The following is a description of a gene set: Human Gene Set: HP_ABNORMAL_ESOPHAGUS_PHYSIOLOGY Any physiological abnormality of the esophagus. species: Homo sapiens Abnormal esophagus physiology, and this is the list of marker genes: VPS37D, AGO1, RET, CACNA1A, AMER1, CHRND, GCLC, TERT, ARHGEF38, GTF2IRD1, EEF1A2, TMTC3, NDUFAF2, VAPB, COL2A1, TBC1D23, SYT2, LRRK2, WAC, CDON, MT-ND1 (NCBI Gene Id 4535), MEN1, ADAMTS2, NEPRO, MGME1, SLC25A1, MT-ND3, LYRM4, WARS2, CACNA1I, STX1A, LUZP1, ERCC6, CNKSR2, GNB5, UNC13A, SLC25A22, CDKN1B, FKBP6, UNC45B, PDPN, SYNJ1, MT-ND5 (NCBI Gene Id 4540), SLC1A3, ASCC3, NEXMIF, ATXN2, SON (NCBI Gene Id 84155), SPG21, FZD2, PRUNE1, HNRNPK, AOPEP, SPTAN1, GPHN, TUBB6, PACS2, ATG7, SEC63, RIC1, SDHB (NCBI Gene Id 96200), KAT6A, ACTB, CDC6, PRDM16, TBC1D24, PGM3, KLHL7, CRYAB, FARS2, ZSWIM6, AAAS, OPA1 (NCBI Gene Id 4976), RETREG1, PIGN, CLCN1, ATP7A, TTC19, FAM13A, TFAP2A, SCUBE3, MYMK, CACNA1C, DAB1, NDUFA13, ARHGAP29, AFG3L2, FARSB, NOP56, SMC5, CACNA1B, POLR3B, TFG, SLC25A24 (NCBI Gene Id 92093), ATXN7, SACS, ARSL, TYMP, TECPR2, TAMM41, YARS2, CASK, SMG9, ITPR1, GABRG2, SPART, YY1, CCDC22, KAT6B, BRAF, GUCY1A1, ATP6V0A1, CPLX1, PUS3 (pseudouridine synthase 3), MAP3K20, LAMA2, ARCN1, NEFL, PRPH, ALG2, NDUFA9, GLI2, ALMS1, MB, NSD2, TRAPPC11, ARF1, PARN, POLR3A, MECP2, DHX9, NDUFA6, EXOSC5, EDEM3, CRLF1, FOXH1, SPG11, CNTNAP1, MT-ATP8, LMNB1, DNAJC30, CSPP1, SPEN, PIK3R5, ADGRG1, GAS1, DNM1, PABPN1, CLIP2, MEGF10, MTHFS, ZIC2, BMP4, GRB10, SETX, SLC46A1, BICRA, PPM1D, SIN3A, COQ4, SLC5A7, TANGO2, MED17, NOS1, TPM3, ARNT2, NTRK2, DISP1, CYP27A1, NKX2-5, COL4A6, BAP1, SLC1A4, ACTA1, GTF2IRD2, CLCA4, PTCH1, SUCLG1, KLHL41, NSUN2, TMEM94, TPM2, TBX4, PTRHD1 (NCBI Gene Id 391356), PRKCSH, ACTL6B, ABCD1, ATP2B3, VPS13A, RAD21, SEC24C, GABRB2, SLC25A4, FBXO7, CTBP1, LRPPRC, HECTD4, ATP7B, SLC6A5, AGR2, SPTLC2, TERC, PRDX3, CHRNE, SMARCA2, SPTBN4, DMXL2, TCEAL1 (NCBI Gene Id 96422), CACNA2D1, MAGEL2 (MAGE family member L2), FGF12, COL1A1, HNRNPH2, GFAP, APOE, MYPN, SRPX2, KY, AFG2A, RNU4-2, GRHL2, CDK13, SCN1B, DNAJB6, AHDC1, KCNA1, CCR6, FGF8, PIGP, ANKRD11, TGM6, SZT2, FMR1, PLA2G6, SLC13A5, ASXL3, CTNNB1, DST, COL13A1, FLCN, TMEM270, PDE8B, UCHL1, ZC4H2 (zinc finger C4H2-type containing), COX11, NPC1, MYO9A (myosin IXA), POR, QDPR, WDR26 (WD repeat domain 26), GCH1, GLYCTK, KIAA0586, HEXB, CDK19, ACADVL, ENSG00000288330, SLC1A2, NFIX, MMP23B, EP300, ALS2, GFPT1, PIEZO1, TAF6, PRPS1, ATXN3, RARS1, PYROXD1, FTL, CHCHD10, ARID2, KMT2B, HMBS, SDHD, UBA5, CAMK2B, EIF5A, SYT14, MT-TL1, LTBP4, HLA-B, CFAP410 (NCBI Gene Id 755), CSF1R, WWOX, CENPT, CASZ1, GBA1, VAC14, GLRA1, FLVCR1, SEC31A, MYOT, STAC3, LETM1, DLL1, MPZ, CAV1, NECAP1, ANXA11, APC2, MAP1B, DDOST, TGIF1, TSEN2, HLA-DQB1, FLII, SMC1A, KCNK9, RHBDF2, TNPO3, GRIN2D, BRD4 (bromodomain containing 4), KCNC2, HRAS, ATL3, NEU1, SCN8A, HGSNAT, CORO1A, CREBBP, DEAF1, VAMP1, DKK1 (NCBI Gene Id 22943), CHMP2B, GDAP2, AFF4, ATP1A3, UBE4B, ELP1, EPG5, STAG2, ABCA3, NEUROD2 (neuronal differentiation 2), PDHA1, PFN1, SHANK3, CHAMP1, DYSF, GABBR2, MAB21L1, TIMM8A, DPP9 (dipeptidyl peptidase 9), SCN9A, ITCH, SRD5A3, SERPING1 (serpin family G member 1), TPP1, SLC35A2, KCNQ2, HIRA (histone cell cycle regulator), SYT1, SNF8, MAPT, SLC26A9, AMPD2, ITGA7, STAG1, RNASEH1, NECTIN1, TP63, DDHD2, TBX1, MEIS2, PRKRA, KIF5A, HDAC8, PIGT, MFF, NSRP1, ARVCF, SCN4A, ATXN10, ZMYM2, MT-TT, FLNC, GNAQ, SCN1A, PSEN1, MAPK8IP3, AFF3, EXT2, AP3B2, ASPA (aspartoacylase), ATP6V1B2, IDH1, MBD5, ACTG2, COL5A2, SCARB2, PHEX, ERMARD, SCN3A, GRIA1, NF1, KNSTRN, RPL10, DPH5, ARX, SFTPA2, CELF2, CYFIP2, SI, SLC19A3, SQSTM1, TRPV6, KCND3, RRM2B, SLC52A2, ACOX1, NEDD4L, RRM1, SLC6A9, ADAT3, PORCN, POLG, ASNS, H3-3A, WFS1, UFC1, GMPPA, PNKP, TUBB4A, LMNA, PAX8, LMX1B, PEX1, TRIO, PANK2, MED12, COLQ, CDKL5, GABRA2, NEB, CTNS, DLG1, CAMTA1, MIF, GTF2I, LRP12, CHAT, NUP62, NGLY1, ALG12, BAZ1B, CLTC, USP7, H3-3B, IRF2BPL, KIT, HSD17B10, KMT2D, KLHL40, FBXW7, FBXO11, PSAP, TRAPPC6B, CACNA1G, TAF1, SLC9A6, GRM7, IKZF1, LIG3, SHH, SNCA, PRKCG, ATP11A, AR, SNRPB, SLC12A2, SFTPA1, MSL3, H4C5, TSEN15, CARMIL2, RLIM, CAPRIN1 (cell cycle associated protein 1), DCTN4, IFT56, FGFR3, ADCY6 (adenylate cyclase 6), HPCA (hippocalcin), RNF170, PRDM13, SLC6A3, MCEE, MSX1, FA2H, GRM1, LBR, EHMT1, VRK1, ARV1, GBA2, PAK1, FIG4, PPP3CA, SPTLC1, SPOP, STIL, SUCLA2, GNB1, SFTPC, SNAP25, NR4A2, PIEZO2, GLT8D1, AQP4, MAP3K7 (NCBI Gene Id 6885), APP, TAF15 (NCBI Gene Id 8148), DNAJC13, MAPK1, MRAP, SPG7, PIGQ, PHIP, ZEB2, NPHS1, ELN, DPYSL5, MED25, MT-ND4, NCAPG2, NCF1 (NCBI Gene Id 653844), EBF3, PEX16 (NCBI Gene Id 9409), MACF1, GLB1, IL6ST, GEMIN4, MT-TW, HIVEP2, RELN, CEP85L, MT-ATP6, NUTM2B-AS1, CYP7B1, SV2A, PARS2, MRPS28, ALDH18A1, CAVIN1, LAMB2, PI4KA, ERCC8, ADAR, NEK1, MT-TK, GNAO1 (G protein subunit alpha o1), SLC2A3, HEPACAM, KMT2A, NRCAM, GLRB, USP9X, MYORG, DHDDS, STAT6, MADD, MYT1L, RTEL1, MYL2, FRG1, TREM2, FZR1, TRAK1, FBXO28, NALCN, FUS, CCDC47, POLR1A, CHRNA3, ASXL1, CDKN2B, HACD1, SIGMAR1, FGF10, DDB1, KCNQ3, MT-ND6, GIPC1, DHCR7, ATN1, MLXIPL (MLX interacting protein like), GMNN, PNKD, COQ2, CNBP, LONP1, CLP1, LRP5, IRF6, MSR1, PHGDH, HPDL, STAT3, HMGCR, HLA-DRB1, CCN2, NIPBL, PMP22, RILPL1, ATP13A2, KCNH1, ATRX, CTCF, AARS1, DMPK, PPARGC1A, SIK1, ERBB4, NODAL, POLR2A, SLC9A3, STXBP1, GALC, GABRA5, DES, STN1, ADAMTSL2, TRIM8 (tripartite motif containing 8), CAD, CDC73, DSP, HTRA1, SUPT16H (NCBI Gene Id 6831), TCF4, TK2, JAG1, HTRA2, GSN (NCBI Gene Id 2934), ASCL1, YWHAG, SRCAP, MGAT2, KCNN4 (potassium calcium-activated channel subfamily N member 4), NAA10, LIG4, MYH11, HMOX1, ATAD1, ALG9, EXT1, TBCD, METTL27, HNRNPA2B1, RARS2, SLC18A3 (solute carrier family 18 member A3), CEACAM3, EIF4G1, PIGA, UBTF, CDKN2C, TYMS, NDUFS3, ORC4, DLX4, MATR3 (matrin 3), EIF4H, IDH2, COMT, SKI, ADNP, REEP1, CEACAM6, ATXN8OS, ORC6, COL5A1, SNCAIP, TBL2, ORC1, ATL1, ANG, FOXP2, KIF1A (NCBI Gene Id 654843), TSPYL1, ZMYM3, MPV17, PHOX2B, NSD1, NOTCH3, NACC1, MUSK, SLC32A1, EPRS1, MYH2 (NCBI Gene Id 4620), MYH14, MT-ND2, WASHC5, PDP1, HLA-DQA1 (major histocompatibility complex, class II, DQ alpha 1), PON3, HFE, PDGFRA, PTS, PRKCZ, ASCC1, IVNS1ABP, AASS, SIX3, GLA, PLIN4, TARDBP, NPC2, COBLL1, UBE3A (ubiquitin protein ligase E3A), VPS35, FLNA, DAO, TBP, ZNF699, ZBTB7A, POLG2, CHMP1A, SPTSSA, COL4A5, IQSEC2, ASAH1, ATP5F1A (ATP synthase F1 subunit alpha), PACS1, MINPP1, KCNB1, SMC3, SATB1, KATNB1, CDH1, SIAH1, PLAA, TIMM22 (translocase of inner mitochondrial membrane 22), ADH1C, STUB1, PCGF2 (polycomb group ring finger 2), NUP214, PLXND1, PUF60, SSR4, NOTCH2NLC, ZBTB18, KDM6A, SCN2A, WNK1, ALDH4A1, XRCC1, DALRD3, PCNA, OCA2, SLC37A4, SALL1, BUD23, TRIP4, ATP6V1A, AGRN (NCBI Gene Id 389836), IL7R, REPS1, LIMK1, GJB1, TSEN54, IARS2, CARS2, EDNRA, PON1, MYO1H, LMOD3, COL7A1, MID1, SH2B1, PON2, DYRK1A, COG7, DGUOK, HNRNPA1, AGO2, SLC44A1, DCTN1, DNAAF4, SELENON, ECM1, PIK3CD, GRHL3, MYH8, MRPS34, TGFB1 (NCBI Gene Id 7040), SOX9, DNM1L, GNB2, CFTR, FXN, JMJD1C, SEC23A, HOXB1, SYNGAP1, TOP3A, FGFRL1, EXOSC9, NONO, TBK1, MUC5B, SDHC, NF2, MECR, CTHRC1, PRMT7, AP3B1, ZFX, SERPINA1, IPO8, NUS1, ATP9A, CHD7, PLCH1, VCP, PYCR1, FOXG1, GCDH, SETBP1, KCNAB2, HPRT1, CCNF, MT-TV, MAN2C1, FGFR1, FBXL4, UFD1, GP1BB, HCN1 (hyperpolarization activated cyclic nucleotide gated potassium channel 1), UBB, FBN1, KCNA2, GSTM3, RREB1, FGFR2, RNF125, MED12L, FTH1, CHRNA1, VPS13C, LIFR, PAX7, SLC2A10, KMT2C, KCNC3, ATXN1, TWNK, REV3L, RERE, CLCN4, GIGYF2, EIF4A2, SOD1, NEFH, TTBK2, CPSF3, GOSR2, OPTN, ARFGEF2, CDKN1A, DTYMK, PLEC, ERF, SLC19A2, FLAD1, VPS11, BLM, CLN8, NUP54, SEPSECS, ZFYVE26, SATB2, SAMD9, GABRD, PSPH, ERLIN2, RFC2, SLC6A14, FERMT1, TSEN34, TRAPPC12, MTRFR, RAI1, GON7, TOR1A, SOX5, GPRC5B, UBQLN2, ADD3, B4GALNT1, VPS35L (VPS35 endosomal protein sorting factor like), SDHA, FCSK, GLE1, KBTBD13, KIAA0319L, IRF5, SLC11A1 (NCBI Gene Id 6556), NDE1, HTT, NAA60, GNAS, RNU4ATAC, SLC38A3, ATP1A2, PYGM, DCX, HNRNPH1, PRNP, GRIN1, MMP1, FKRP, GNS, POGZ, CRIPTO, VARS1 (valyl-tRNA synthetase 1), TNNT1, NTRK1, MRPS25, DDC, OCRL, MAP2K2, TRMT10C, PLP1, NRXN1, HSPG2, NDUFS1 (NCBI Gene Id 55372), SEMA3E, ABCD4, SLC52A3, TWIST1